Given this list of marker genes H2-DMb2, H2-Ab1, H2-DMa, H2-DMb1, H2-Oa, H2-Eb1, Cd74 (CD74 antigen (invariant polypeptide of major histocompatibility complex, class II antigen-associated)), Cd4, H2-Ob, B2m, H2-Ea (NCBI Gene Id 14968), H2-Aa, H2-Eb2, here is a description of the gene set: Mouse Gene Set: GOMF_MHC_CLASS_II_PROTEIN_COMPLEX_BINDING species: Mus musculus Binding to a class II major histocompatibility complex.